The following is a description of a gene set: studied in species Mus musculus Mouse Gene Set: CUI_B_CELL_IL7_RESPONSE_DN Genes negatively differentially expressed in cell type: B cell upon treatment with cytokine: IL-7 in mouse lymph nodes in vivo. from publication Cui A, Huang T, Li S, Ma A, Pérez JL, Sander C, Keskin DB, Wu CJ, Fraenkel E, Hacohen N (PMID 38057668) Cytokines mediate cell-cell communication in the immune system and represent important therapeutic targets. A myriad of studies have highlighted their central role in immune function, yet we lack a global view of the cellular responses of each immune cell type to each cytokine. To address this gap, the authors created the Immune Dictionary, a compendium of single-cell transcriptomic profiles of more than 17 immune cell types in response to each of 86 cytokines (>1,400 cytokine-cell type combinations) in mouse lymph nodes in vivo. A cytokine-centric view of the dictionary revealed that most cytokines induce highly cell-type-specific responses. For example, the inflammatory cytokine interleukin-1β induces distinct gene programmes in almost every cell type. A cell-type-centric view of the dictionary identified more than 66 cytokine-driven cellular polarization states across immune cell types, including previously uncharacterized states such as an interleukin-18-induced polyfunctional natural killer cell state., and this is the list of marker genes: Ccr6, Klf2, Fos, Hspa1b, Cxcr4, Ccr7, Tsc22d3, Fosb